Given this list of marker genes CA14, MYL3, CLIP2, GEMIN7, SPEG, TUT1, NR4A3, WDR81, GRM7 (glutamate metabotropic receptor 7), DZANK1, PLPPR2, TUBA1C, ALKBH5, RORC, LRP1B, NECAB3, KRT36, SERPINB5, LINC00472, KAT8, C8orf82, SMOX, UFD1, BNIP3, LRP1, TOMM70, OMG, ROM1, RSPO2, DTNA, SYT2, MCAM, TINAG, ADAM23, HSPA9, MIR22HG, LTA, CNBP, BBLN, NAP1L5, SLC8A3, KDELR2, POP1, OSTC, KLHL11, TBXAS1, ANGPT1, FGF1, MTMR4, PAFAH1B1, CDC45, PPP2CA, SMARCA2, PPP2R2B, PADI4, OSER1, ARF4, ZNF296, UNKL, DRP2, MYH13, TANGO2, EIF5, RASAL1, NANOS1, SEL1L3, KCTD4, SEC23A, AHNAK, NRG1, DTX2, FBXO2, FGF11, KCNA6, CAMKK1, SZT2, GAL3ST4, JAZF1, SAMD12, TOB1, PTGES3, BCL6, PCDHAC2, PSMD8, NR6A1, SNTB2, MIR9-1HG, ATL1, CMAS, TMEM263, FOXG1, BAHD1, AAK1, OSBP, CDK9, HSP90AB1, PRDM1, STMN2, SNCB, SQSTM1, DYNC1I1, ENO1, SLC50A1, FTSJ3, PRR7, PLEKHH3, RNF182, PTPRN, EEF2, SSR1, KRT33B, GAST (gastrin), MMP9, ANP32E, BARHL2, SUMO2, NUDT11, CST7, TUBA4B, CDC42SE1, DUSP2, FMNL1, DUSP13B, RHO, ATP2A3, MDGA2, TOX2, MLLT11, MYO1C, RABGGTB, DHDDS, GOLM2, CDON, LARP4, SGMS1, PTGES2, TBL1X, PSMB1, ASAP2, ASPSCR1, VASP, PPARG, EMB, CRYGN, TREML2, SMPX, LIN54, VPS26A, RAG1, ABCF3, CPNE6, CLCN5, SLC16A6, TPM3, PLEC, IQGAP1, FOXP2, RARG, RNF13, RHOG, BSCL2, AP1G1, SRCIN1, ABCB6, SPATS2, MYOC, ESR1, BLMH, LINC03124, DOCK4, MAPK3, BAZ2A, BACH1, GK, CBX6, TUBA4A, KRT27, NABP2, GADD45G, COLCA1, PSMD7, DLG3, CD2AP, NUDT10, PSMA1, HOXB8, ACO1, TMEM47, ALDOB, PHF21B, CLTC, SIX6, CD200R1, BTK, CAVIN2, NRXN2, GNG3, CACNB1, JADE1, CIRBP, P2RX6, ABCA7, METTL2A, PLBD2, RAB5IF (NCBI Gene Id 55969), DDX17, KRT13, NTPCR, NEDD9, FGF9, RAN, FCHSD1, CIPC, SLC25A51, RPL23, ITPRIP, TYRO3 (TYRO3 protein tyrosine kinase), GPD1, TSPAN17, FBXO44, NAP1L2, HINT1, USP34, TLR8, GADD45A (NCBI Gene Id 1647), LYVE1, RFTN2 (NCBI Gene Id 130132), FBLN2, PSMB2, KCNH3, VCP, SPTLC2, TLL1, C1orf122, PSMC5 (NCBI Gene Id 5705), MAPK10, PIK3C2B, TXNL1, GABARAPL1, ANKS1B, ARRDC3, CDC37L1, ATP1B1, SLC22A18, GAPDH, IPO11, GSTP1, RIDA, CPXM1 (NCBI Gene Id 56265), SOX5, SEPTIN9, IL6, SLC22A18AS, GAB2, LINC02694, CPZ, SUMO4, TFEC, KCNAB1, HSPB3, CBY2, CTNND1, SNX10, HNRNPR, DNAJC7, METTL2B, TBP, YWHAG, RAB6A, ANGPTL4, PFKFB1, SEC24D, DMD, TBL1Y, MIA2, UBE2D1, FLNC, NKIRAS2, SAMD7, RYR1, CRH, WDFY3-AS2, EML3, NDUFC1, KCND1, HNF1A, SERTAD4, HDLBP, TFAP2D, TMCC1, PIM1, SLC35B1, MAP4, FAM83H, CFL2 (cofilin 2), SLC7A8, TTLL7, PSMD11, CYTOR, WDFY3, RBBP7, MAPK12, BRD2 (bromodomain containing 2), TSPAN13, UCHL1, ABCC6, KLHL3, here is a description of the gene set: Comprehensive identification of all functional elements encoded in the human genome is a fundamental need in biomedical research. Here, we present a comparative analysis of the human, mouse, rat and dog genomes to create a systematic catalogue of common regulatory motifs in promoters and 3' untranslated regions (3' UTRs). The promoter analysis yields 174 candidate motifs, including most previously known transcription-factor binding sites and 105 new motifs. The 3'-UTR analysis yields 106 motifs likely to be involved in post-transcriptional regulation. Nearly one-half are associated with microRNAs (miRNAs), leading to the discovery of many new miRNA genes and their likely target genes. Our results suggest that previous estimates of the number of human miRNA genes were low, and that miRNAs regulate at least 20% of human genes. The overall results provide a systematic view of gene regulation in the human, which will be refined as additional mammalian genomes become available. from publication Xie X, Lu J, Kulbokas EJ, Golub TR, Mootha V, Lindblad-Toh K, Lander ES, Kellis M (PMID 15735639) Human Gene Set: TGANNYRGCA_TCF11MAFG_01 studied in species Homo sapiens Genes having at least one occurrence of the highly conserved motif M67 TGANNYRGCA in the regions spanning 4 kb centered on their transcription starting sites. This matches the NFE2L1, MAFG transcription factor binding site V$TCF11MAFG_01 (v7.4 TRANSFAC).